The following is a description of a gene set: Human infertility and recurrent pregnancy loss caused by implantation defects are poorly understood. Hoxa-10-deficient female mice have severe infertility and recurrent pregnancy loss due to defective uterine implantation. Gene expression profiling experiments reveal that Hoxa-10 is an important regulator of two critical events in implantation: stromal cell proliferation and local immunosuppression. At the time of implantation, Hoxa-10 mediates the progesterone-stimulated proliferation of uterine stromal cells. Hoxa-10 mutants express a stromal cell proliferation defect that is accompanied by quantitative or spatial alterations in the expression of two cyclin-dependent kinase inhibitor genes, p57 and p15. Hoxa-10 deficiency also leads to a severe local immunological disturbance, characterized by a polyclonal proliferation of T cells, that occurs in place of the normal progesterone-mediated immunosuppression in the periimplantation uterus. species: Mus musculus from publication Yao MW, Lim H, Schust DJ, Choe SE, Farago A, Ding Y, Michaud S, Church GM, Maas RL (PMID 12554760) Genes co-regulated in uterus during a time course response to progesterone: SOM cluster 15. Mouse Gene Set: YAO_TEMPORAL_RESPONSE_TO_PROGESTERONE_CLUSTER_15, and this is the list of marker genes: Mterf2, Alox15, Cd59a, Col4a5, Xpa, Mki67, Pclaf, Stmn1 (stathmin 1), Nsg2, Grn (NCBI Gene Id 14824), Nicol1 (NCBI Gene Id 381633), Epor, Heph, Robo1, Lum, St3gal6, Ptprd (protein tyrosine phosphatase receptor type D), Kif22 (kinesin family member 22), Sema3b, Septin10, Itm2a, Dnase1l2, Col14a1, Gbp3, Pck2, Gab1, Sema3c, Npc1, Cryz, Postn, Plac8, Gstt1, Aurkb, Slc15a2, Birc5, Cdk1